Given this list of marker genes CYP2J2, VAMP5, CREM, ATF5, MMP19, NCAM1, MST1R (macrophage stimulating 1 receptor), SLC52A1, CCL4, TDO2, BST2, LDAF1, KCNE5, CXCL13, GCNT1, TLR3, PROCR, AGRN, PLEKHG7, RFPL3, TRIM69, HPSE (NCBI Gene Id 10855), DLGAP1, LDHAL6B, CCR1, ACP2, RSAD2, MYO1E, ACSM5 (acyl-CoA synthetase medium chain family member 5), CGAS, SIDT1, PFKP, CXCL10, RNASE2, CEMIP, CYP7B1, SLC38A5, RGMA, UBE2QL1, PTPRU, ZNF620, SMAGP, IRF4, NFE2L3, TICAM1, RAPGEF5, CSF1, PRUNE2, PLEKHA7, AK4, CENPJ, HLA-L, BCL2L13, MAFF, P4HA2, ANK3, LRRC3, STAT1, HCAR3, BMAL2, PLEKHD1, OSBPL5, C2, KCNN1, RIN2, BIRC5, ADPRH, TCN2, TGM1, FBXO6 (NCBI Gene Id 55822), IFIT2, LINC03040, TGFA, IFI35, FAM53A, ENTHD1, ZSWIM4, HDX, IFIH1, CEACAM1, CLEC4F, COL4A2 (NCBI Gene Id 1284), H2AC7, NADK, USP30-AS1, TTC7B, SLC1A4, ANKRD29, CASP1, EPOP, MROCKI, CYP27B1, RIGI, IDO2, TAP1, PLEKHA4, APOBEC3F, ACHE, TNFAIP6, LILRA3, MAP2, MGC16275, SLC2A6, PARP14, ZNF365 (zinc finger protein 365), AMOTL2 (angiomotin like 2), DLL4, UBQLNL, SAMD9, GCNT2, IL3RA, IPCEF1, PRRG1, SRD5A1, TRIM56, DSP, FAR2, CD274, MTCL3, GJB2, EGR2, ELL3 (elongation factor for RNA polymerase II 3), NBN, SLC2A12, DAPP1, SAMD9L, TNFSF13B (NCBI Gene Id 89794), RIPK2, CBR1, TNFSF4, PHGDH, KIR2DL4, TRIM26 (tripartite motif containing 26), IFI44, HLA-G, NHSL3, LRRC32, HCG4, ADORA2A, SUPT3H, VWA5B1, ARMCX1 (armadillo repeat containing X-linked 1), FKBP1B, OTOF, NEURL1, PPP2R2A, KLF5, CDK18, ACSL1, AIM2, PI4K2B, LIF, RUBCN, VRK2, SASH1, STIMATE, SCML4, SLFN13, MAPK8IP2, TLR2, LHFPL1, TMPRSS3, SSTR2 (somatostatin receptor 2), RILP, CD80, CARD17P, GPRIN1, MOV10, DNAAF1, ADGRB1, LHFPL6, MSR1, B4GALT5 (beta-1,4-galactosyltransferase 5), IFIT3, IGFBP3, MGAT3, HAPLN3, TP53INP2, IRF7, ANXA10, RASGRP3 (RAS guanyl releasing protein 3), COBL, AMER1, TRPM4 (transient receptor potential cation channel subfamily M member 4), NRSN2 (neurensin 2), SP100, STBD1, HBD, RNF122, SCARB2, ADPRS (NCBI Gene Id 54936), SRGAP2, ANKRD22, KIAA0040, DYNLT1, TMEM106A, SLC25A28, FOXC1, POGLUT3, SPTA1 (NCBI Gene Id 6708), PACSIN3, TRIM36, C1R, PRICKLE1, KCNS3, PIWIL4, ITGB8, DDX60L, TRAFD1, TLNRD1, GBP4, PTPRS, DNAJC5B, USP42, SECTM1, H2AC6, AIFM2, SRC, BAG1, HRH1, SELENOO, TRAF1, CASZ1, RUFY4, ETV7, ECE1, DYSF, H3C13 (H3 clustered histone 13), CCL3L3, SOX8, TRIP6, SLC6A9, H3-5, MCOLN2, RHOC, ITIH4, CIR1, AKT1S1, SCT, FXYD6, CCN2, BRIP1, EIF4E3, MT1M (metallothionein 1M), NR4A3, UBE2S, STON2, NMI, B3GNT2, ZNF684, AP5B1, RBCK1, PLS3, IFNG, IL2RA, UBE2L6, CD2AP, ADM, MIR4645, CD200, LHFPL2, NINJ1, EDARADD, LTA, STX11, WHRN (NCBI Gene Id 8016), CIB2, GPR155, ARID5A, PTGER2, ARHGEF11, SRGAP2B, LMNB1, CDK1, BACE2, LAMP5, GBP7, CD40, TUBB2A, CDKN1C, FGD2, PPM1J, TTC21A, FAM3B, AK8, SUSD1, PAPLN, BRSK1, PSAT1, LAP3, KIF19, IL7, OLIG2, UPB1, FFAR2, PXDC1, PANX1, ARID5B, BUB1, ADGRE1, TRIM14, DACT3-AS1, OASL, SYNPO, MOXD1, OR52K2, EXOC3L1, SERTAD1, CECR2, SERPINB9, H2BC11, PRR5-ARHGAP8, FRRS1, BAALC, TMOD1, L3MBTL4, DNAH8, XAF1, GPBAR1, NUPR1, MAP1A (microtubule associated protein 1A), FCRL4, OAS3, RSPH9, CASP4, BAMBI, CDC42EP2, BTG3, TICAM2, GJA3, ELOVL7, SLC37A1, PGAP1, CLEC4C, PRKD2, PRRG4, LINC-PINT, DBF4B, OR52B6, RNF213, ABHD17C, LAMP3, PRLR, SPATS2L, CLLU1-AS1, CCDC80, MYO16, PRDM16, CASP10, TRANK1, FMNL2, LINC00189, STOM, SMIM3, PAX5, ISG15, SNX10, SERPING1, MIR4750, TRIM5, BAK1, CKAP4, TMTC1, USP18, GBP2, FIRRE, GBP6, PILRA, GPR141, WNK2, DPYS, PLSCR1, ADAMTS2, FANCA, GRIP1, SPHK1, ACSM1, MX2, MOB3C (MOB kinase activator 3C), LGALS2, SIGLEC14 (NCBI Gene Id 100049587), LILRA6, PARP10, PDGFRL, H2BC5, APOBEC3G, HES4, ELF4, JAK2, ITIH1, FUT4, DMD, P2RX7, ACOT9, CPEB3, CDKN2A, MXD1, STOML1, DUSP6, DLL1, SMTNL1, CYP4F11, ZCCHC2, PHF11 (PHD finger protein 11), KIAA1217, IL15RA, IFI27, ELOVL3, KPTN, ZC3HAV1L (NCBI Gene Id 92092), TMEM140, ISG20, CTNND2, CACNA1A, TMEM178B, MT1E, SQOR, MRPL44, ANKRD1, KLF6, NSUN7 (NCBI Gene Id 79730), NOD1, TMEM139 (transmembrane protein 139), KRT5, DNAI3, DDX60, TMEM187, C3orf52, C17orf67, RELB, NKX3-1 (NK3 homeobox 1), SBK1, IL4I1, TFEC, FAM72D, OLIG1, IGF2BP2 (NCBI Gene Id 10644), MELK, TPX2, N4BP1, SAMD4A, NRIP3, TMPRSS13, CYSTM1, LY6E, PNPT1, MTHFD1L, XCR1, TMEM229B, CD72, IFITM2, ARK2C, PDE4B, CDC45, MICALL1, CAVIN3, C1GALT1, MICB, SLC22A16, TRIM6, LRP12, RASGEF1B, VAV3, TTC39B, CD83, BRCA2 (NCBI Gene Id 82716), ZBP1, SMPD3, IER5, PRG2 (NCBI Gene Id 87065), CETP, HK2, MAML2, CASP7, EPHB1, COL24A1, STAP1, CXCL12, YEATS2, HDC, SAMSN1, EDN1, GPD2, LINC00173, GCH1, CCDC42, SLAMF7, NDC80, CDKN1A, CYP1A1, SLC6A8, JAG1, MDK, CBLN3, WNT5A, PML, DNAJC6, GPR161, C4orf36, GTPBP1, INAFM1, LINC00487, BPGM, CHRNB2, KIAA0408, MSC, SDS, TMEM62, PPM1K, SIGLEC1, LGALS9, RNF43, GPR15, CPEB2, KAT14, NAA25, RGS13, HERC6, CCDC146, TNK2, PARP12, GLP1R, GMPR, ITPKA, DNAH12, CHSY1, TANK, NAPA (NSF attachment protein alpha), PABIR3, TSPAN5, SH2B2, DRAP1, WARS1, MASTL, WDFY1, DIRC3, TPSAB1, KCNK15-AS1, USP6NL, DENND1B, NLRP7, EEF1A2, PRRT2, CCR10, FBXO39, GTPBP2, SLC24A3, IL36RN, FZD4, IL6, TUFT1, SOCS2, LINC00996, FNIP2, CCL18, OAS1, TIAM2, CH25H (NCBI Gene Id 9023), MACROD2, P2RX4, FAS, FAM225A, ADCY4, SSTR3, IDO1 (NCBI Gene Id 3620), TCHH, CHAC1, TRADD, EIF2AK2, PTOV1-AS1, BBS12, LINC00161, TNFRSF13B, SLC7A5, ILDR1, KCNK5, CCL19, H2BC4, DNASE1L3, SLFN12, MIR9-1HG, CCDC9, KITLG, NECTIN2, DOP1A, SHOX2, FFAR3, CCL2, IRF2, SLC39A8 (NCBI Gene Id 64116), RNF19B, IFIT1, KCTD19, UBE2C, OAS2, TAP2, RBM11, RAB20, ZNG1A, CLDN23, ATP10A, SORBS1, IL12RB2, SLFN12L, GUCY1B1, TMEM277P, FAM72B, GBP1, DDIT3, FNDC11, JMJD1C-AS1, LGALS3BP, GUCY1A1, PANX2, CPNE5, PHEX, PLEKHN1, KCNA2, JUP, MEFV, DNAJB4 (NCBI Gene Id 11080), ST3GAL5, ZNF267 (zinc finger protein 267), CCL8 (NCBI Gene Id 96488), CNP, TMEM150B, CFLAR-AS1, DUSP1, HELB, ZNF107, HLX, TSPAN13, PLA2G4C (phospholipase A2 group IVC), HS3ST3A1, PNOC, BAZ1A, LINC01531, ZBTB42, GREM1, APOL6, ENDOU, RUNX2, HSH2D, SCIN, RTCB, IL1RN (interleukin 1 receptor antagonist), ABHD16B, WNT10A, APOL1, OSBPL6, C1QTNF1, FAM47E, BATF2, TDRD7, PROB1, LILRB4, TOR1B, CHODL, CDC42EP1, PARP9, ZNFX1, FLT3, SEMA4A, DTX3L, ADM2, HLA-DOB, SCG3, H2BC18, MYO7B, KCNJ2, TUBA1C, LIMCH1, MZB1 (NCBI Gene Id 51237), KLHDC7B, HESX1, DHX58, CHST7, SOCS1, SDC3, CFB (complement factor B), EPHA2, RAPGEF2, ICAM1, LAMB1, XRN1, CMYA5, MYO10, BSPRY, IGF2BP3, FNDC3B, FRMD3, IGFBP4, CCR5, GLI3, IRAK2, TRIM25, DRAM1, C1orf226, C5, CCL3, FOSL1, MELTF, TREX1, NGFR, PDCD1LG2, RAB39A, RHBDF2, TRIM38 (NCBI Gene Id 10475), GBP3, NCOA7, KDM6A, SOBP, EMP1, LINC00960, PLSCR4, SP110, ASCL2, PRR5, H4C12, NUB1, APOBEC3B, BATF3, CD70, MX1, MAMLD1, GRHL1, ENDOD1, LYSMD2, MT2A, ITGA7, IRF1, SPSB1, ZNF366 (zinc finger protein 366), CTSL, FASLG, CARINH, ANKRD45, ADAM19, SOAT1, HELZ2, SYNPO2, NDUFC2-KCTD14, MIR320E, LINC02363, CMTR1, IL12A, CMPK2, LPAR1, MVB12B, TJP2, CES1, CALHM6, RGS20, TBC1D17, SLCO5A1, C15orf48, SERPINH1, NEXN, RHEBL1, CLMP, ARHGEF3, E2F7, PTTG2 (NCBI Gene Id 10744), GPR180, AANAT, SLC31A2, ARL5B (NCBI Gene Id 221079), NBPF7P, CSRNP1, SLC8A1, CDH1, ACSBG1, NACAD, GRIN3A, SLC35F3, TRAF2, OSM, ARHGEF10L, IL27, PAX8, NRXN2, HERC5, MAPK11, TRIM22, SLC12A3, MOCOS, LILRB2, CD38, PRR16, DCDC1, CORO2B, ABCD1, RET, PTGDS, RAPGEF3, CDKN2B, HIRA, KCNMB1, NKAPL, LSS (lanosterol synthase), GAREM1, C1S, RAB19, CXCL9, CALD1, PLEKHH1, DYRK3, ELMO2, IFITM3, TUBB3, ARHGAP23, NEURL3, TMEM217, PERM1, ELFN1 (NCBI Gene Id 652055), LYN, TTC39A, ATP13A2, CUX2, CCNA1, LILRA4, STIMATE-MUSTN1, SCO2, PCGF5, GALNT8, NECTIN3, CR1L, H4C8 (NCBI Gene Id 8365), HMMR, MDGA1, ATF3, UBE2Z, CLEC12B, H3C4, RTP4, PKMYT1, APOBEC3A, TSC22D1 (TSC22 domain family member 1), MYO1G, ARNT2, CHST12, DCUN1D3, JADE3, POU5F1B, BLZF1, CASP5, PLSCR2 (NCBI Gene Id 57047), PAX8-AS1, CKB, CD109, SLC41A2, SP140, BCL2L14, LY6E-DT, SYPL2, MEP1A (meprin A subunit alpha), LILRA5, MCM10, PRECSIT (p53 regulated carcinoma associated Stat3 activating long intergenic non-protein coding transcript), SYTL3, ERICH3, TMEM255A, HDAC9, CASP3, TMEM26, ZNF462, BARD1 (BRCA1 associated RING domain 1), TMEM244, STAT2, FERMT2, AMBRA1, FSCN1, PYCR1, CLECL1P (C-type lectin like 1, pseudogene), EPSTI1, ADAMDEC1, AXL, TNF, INHBA, STRIP2, CCL7, TRIM21, IFI44L, ACAN, SHFL, SCAMP5, DUSP5, MUC1, SMCHD1, MEIS3 (NCBI Gene Id 56917), KY, CCRL2, ADPGK-AS1, PDCD1, MIR3945HG, IRS1, TMEM171, NIPAL4, OSBPL1A, TENT5A, ZNG1B, GBP5, PSMB9, ZSWIM5, FAM72A, NOD2 (NCBI Gene Id 8135), ZNF618 (NCBI Gene Id 4740), SLC30A4 (NCBI Gene Id 7782), ADGRF3, CHI3L2, PLVAP, ABTB2, IFIT5, NFIX, ODF2L, LAG3, PSEN2, TNFSF10, ITGA2, TJP1, DIP2C, PARP11, EHD4, TCAF2, MIR155HG, LRRN2, IL15, PARP3, LPAR3, OPTN, PHLDA2, ANKRD53, TMEM200A, ACTA2, SCLT1, ASPHD2, LGALS9B, LYPD5 (LY6/PLAUR domain containing 5), IFI6, TENT4A, SLC27A2, APOL2, CLDN14, ANKRD33B, PMAIP1, IFITM1, LPIN2, APOL3, ENPP2, KCNE1, NR1H3, ADAMTS14, CXCL11, PPP1R15A, HCAR2, NTN1, TUBB2B, RBM43, ZNRF2, CD69, PRG4, DCSTAMP, TMEM268 (transmembrane protein 268), RGS1, SLC22A4, ZBTB32, BAALC-AS2, ST8SIA4, MYBL2, NCF1, CHRNA6, ESPNL, KCNJ10, here is a description of the gene set: from publication Haralambieva IH, Zimmermann MT, Ovsyannikova IG, Grill DE, Oberg AL, Kennedy RB, Poland GA (PMID 27529750) BACKGROUND: There are insufficient system-wide transcriptomic (or other) data that help explain the observed inter-individual variability in antibody titers after measles vaccination in otherwise healthy individuals. METHODS: We performed a transcriptome(mRNA-Seq)-profiling study after in vitro viral stimulation of PBMCs from 30 measles vaccine recipients, selected from a cohort of 764 schoolchildren, based on the highest and lowest antibody titers. We used regression and network biology modeling to define markers associated with neutralizing antibody response. RESULTS: We identified 39 differentially expressed genes that demonstrate significant differences between the high and low antibody responder groups (p-value <= 0.0002, q-value <= 0.092), including the top gene CD93 (p < 1.0E-13, q < 1.0E-09), encoding a receptor required for antigen-driven B-cell differentiation, maintenance of immunoglobulin production and preservation of plasma cells in the bone marrow. Network biology modeling highlighted plasma cell survival (CD93, IL6, CXCL12), chemokine/cytokine activity and cell-cell communication/adhesion/migration as biological processes associated with the observed differential response in the two responder groups. CONCLUSION: We identified genes and pathways that explain in part, and are associated with, neutralizing antibody titers after measles vaccination. This new knowledge could assist in the identification of biomarkers and predictive signatures of protective immunity that may be useful in the design of new vaccine candidates and in clinical studies. Human Gene Set: HARALAMBIEVA_PBMC_M_M_R_II_AGE_11_22YO_VACCINATED_VS_UNVACCINATED_7YR_UP Genes up-regulated in peripheral blood mononuclear cell vaccinated vs unvaccinated in adolescent/young adults (11-22) after exposure to M-M-R II, time point 7Y studied in species Homo sapiens